Given this list of marker genes SLC22A4, SLC22A2, RUNX1, SLC22A5, SLC22A16, SLC22A3, SLC22A15, SLC22A1, SLC22A18, RSC1A1, here is a description of the gene set: Human Gene Set: REACTOME_ORGANIC_CATION_TRANSPORT species: Homo sapiens Organic cation transport